The following is a description of a gene set: Genes containing one or more binding sites for (Vsx2) in their promoter regions (TSS -1000,+100 bp) as identified by GTRD version 20.06 ChIP-seq harmonization. Mouse Gene Set: VSX2_TARGET_GENES from publication Yevshin I, Sharipov R, Kolmykov S, Kondrakhin Y, Kolpakov F (PMID 30445619) species: Mus musculus, and this is the list of marker genes: Atp6v0e2, Dedd, Zfp472, Tdrkh, Pyroxd1, 1700065J11Rik, Zfp473, Ddc, Pdcd2, Six3os1 (NCBI Gene Id 77868), Icosl, Mrpl54, Elf2, Rad54b, Cactin, Gins4, Ecpas, Vrk3, Ash1l, Tipin (NCBI Gene Id 74321), H2bc15, Lrp2bp (Lrp2 binding protein), Skil, 5730596B20Rik, Mir1906-1, 4930512B01Rik, Etl4, Wscd2, Gm15340, Trrap, Dock5, Cipc, Siah3, Idh1, Inpp4b, Mdm4, Arhgap28, Bcar3, Nfyb, 1700113A16Rik, Rnf207, Zhx3 (zinc fingers and homeoboxes 3), Nedd4l, Trim33 (NCBI Gene Id 99609), Slc12a4, Cyb5r4, Crip1, Tlr3, Ndufa9, Wdr1, Gm21917, Gm13761, Slc16a3, Gm13648, Lmo2, Plcb3, Mrpl9, Rab3ip, Gm30382, Pkn2, Zfp595, Mir1191b, Alkbh1, Sec24d, Zcchc10, Mir34c, Rps6kb1, Mbd3l2, Snora28, Snx16, Zbed6, E130304I02Rik (NCBI Gene Id 78547), Otx2os1, Slc39a13, 4930461G14Rik, Cdh22, Elmo2, Gm11728, Myo3b (myosin IIIB), Zfp763, Dffa, Ulk4, Mutyh, Deptor (NCBI Gene Id 97998), Man2b2, Ascc1 (activating signal cointegrator 1 complex subunit 1), Mettl15, Epc2 (NCBI Gene Id 51924), Pnrc2, Elf3, Prdm9, Gpr85, Opn3, Nabp1, Cyp4b1-ps1, Palm3, D1Pas1, Grk5, Rpl35a-ps3, Kctd12, Tmem229b, Abcg2, Chp2, Krtap4-16, Mir195a, Fndc3a, Jund, Dlx1as, Tbc1d10a, Gm24432, Mif, Ubr4, Cfap77, Gm12229, Cdk2ap1rt, Gsto1, Fbxo9, Med18, Gm22215, Gm11536, 4632428C04Rik, Cyp2j13, Tmed6, Adprm, Gramd2b, Ampd2, Gm3143 (predicted gene 3143), Sf1, Gm13655, Slc35b1, Gm24616, Smim18, Prkar1b, Nat8f2, Mir6359, Rnf135, Gm11587, Mrpl22, Zfp532, Pecr, Bnipl, Epb41, Csrnp3, Mef2c, Txndc12, Enpp5, Ly96, Gm30948, Zfp982, Gm29246, Setd1b, Pgrmc2, Ier2, Gm24784, Gm16326, AI987944, Neurl4, Mdga1, Mir7009, Gli2, Cyrib, 5830454E08Rik, Haus3, Gypc, Gtf3c2 (general transcription factor IIIC, polypeptide 2, beta), Prkab2, Mab21l1, Rcc1, Calm3, Rbm14, Gm25724, Vars2, Rell1, Alyref, Gm24998, Trib3, 6530411M01Rik, Nup43, Rhox12, Tmem259, Gjd4, Ndnf, B9d1os, Snx17, 9030619P08Rik, Gm6394, Cdc7, Bcat2, Skida1, 2310014F06Rik, Tesk2, Bsdc1, Rmnd5b, Acoxl, Gm6139, Utp15, Rpl26, Poll, Bid, Bfsp2, Tead1, Gm23301, Platr9, Arl1, 1700058P15Rik (NCBI Gene Id 73377), Pip5k1c, Gm8242, Rbm28, Rbm25, Mir5130, Smoc1, Stk39, Pnma2, Dock6, Phrf1, Cabyr, Suclg1, Zfp974 (zinc finger protein 974), 5730488B01Rik, Gm29455, Ldlrap1, Osbpl10, Gm22042, Coro6, Anapc13, Tmem161a, Zzz3 (NCBI Gene Id 99926), Slc23a2, Cobl, Chmp4c, Med21, Dmap1, Brd3, Rorc, Zfp985, Vps13d, Adam22, Ttf1, Acvr2b, Mir496b, Trim47, Tmem131l, Nrg4, Gemin5, Ptgfrn (NCBI Gene Id 99830), Mir664, Jmjd6, Zfp989, Per1, Calu, Cldn22 (claudin 22), Gm28043, Katnal1, Cer1, Dnaaf2, Cdh6, Tardbp, Mcu, Ccdc25, Cep15, Dennd6a, Snord80, Ttll10, Acadm, Rps23-ps1, Nkx2-1, Pank1, Mlip, Tsr1 (NCBI Gene Id 216950), Zfp988, Lypd1, Tram1l1, Dnm2, Gata4, Ywhaq, Prtg, Gm10774, Gm9967 (predicted gene 9967), Gbf1, Gm7902, Zfp984, Cast, Col9a1, Isca1, Mat2b, Gm26447, Gatad2b, Samd7, Pbx2, Ubr1, Fam53c, F830115B05Rik (RIKEN cDNA F830115B05 gene), Triobp, Ptpre, F10, Dok5, Elmo1, Rnpep, 1700011L22Rik, Foxg1, Gm13429, Gbp11, Lrrc28, Trafd1, Sdk1, Gm18808, Mir124-2hg, Lactbl1, Fbxw17, Gm22205, Bola1, Gtf2i, Postn (NCBI Gene Id 99708), 1700003F12Rik, Mcmbp, Ifrd1, Rack1, Cs, 4833420G17Rik (RIKEN cDNA 4833420G17 gene), Bcl7c, Sh3bp1, Zfp703, Oosp3, Tmem144, Sf3b1, Knl1, B530045E10Rik, Mfap3l, Rpe, Tnfrsf22, Dpep1, Etv1, Mrps5, 4930518J20Rik, Insm2, Dock4, Gm12784, Fbrsl1, Park7, Gm13450, Tmem169, Spring1, Cga, Gm12703, Pkm, Thumpd3, Kctd15, Egf, Prkag2 (NCBI Gene Id 73700), Hyal3, Ogfrl1, Rreb1, Pnkd, Srsf3 (serine and arginine-rich splicing factor 3), Wdr73, Gatd3a, Gm12644, Mir690, Aire, Wdr44, Fam135a, Mrpl16, Crym, Tcte2, Camta2, Nkapl, Srpk1, Gm23202, Enah, Gm12101, C4bp, Map3k3, Cdk16, Hcrt, Isoc2a, Tex261, Gm23102, Ubxn2a, Rpia, D7Ertd443e, Mir135b, Fhl1, Or52e5, Kif27, Kif5c, Tspan18, Capns1, Fbf1, Zc3hav1, Krtap12-22, Rps19-ps11, 9330198N18Rik, Rptor, Esx1 (NCBI Gene Id 13984), Pex13, Zfyve16, Hsd17b4, Slc19a2, Gm22301, Nt5c3, Mta3, Krtap2-20, Chrac1, Ap2b1, Acvr1, Ifi30, D630039A03Rik, Slc9a2, Abhd3, Med6, Fcgbp, Acss2, Snap91, Hoxc12, Gm26832, Mvb12b, Cct6a, Ap1ar, Fam167b, Gm23212, Gm15541, Traj27, Ipo8, Osbpl3, Rnf8, Gm13147, Fam169a, Rab11fip3, Tmcc2 (transmembrane and coiled-coil domains 2), Cep120, Fzd2, Mreg, Kdr, Or5m13b, Rnf14, Svopl, Rpusd3, Meg3, Shroom3, Zcchc14, Kif18a, Atp6v1f, Trim6, Adgrl2, Sbds, Urgcp, Gas5, Bahd1, Thra, Gm15770, Phip, Mir370, Ptgr3, Zfp268, Kbtbd7, Itga3, Tanc1, Cyp2u1, Slc25a12, Fmo4, Pisd, Zscan5b, Gm6089, Mir7239, Tmem230, Or52n20, Zfp536 (NCBI Gene Id 78852), Trp53cor1, Tmem275, Mme, Fam131a, Zc3h11a, Trmt44, Gnas, Alas1, Taf1c, Pkdcc, Zfp1, 4833439L19Rik, Rab23, 3222401L13Rik, Lrriq4, Paqr8, Palb2, AU041133, Mfsd4b4, Platr16, Or1j11, Plxnc1, Rad54l (NCBI Gene Id 99991), Gpr153, Pomt2, Gm12508, Fryl, Calm2, Eps8l2, Hyou1, Cnot7, Nlgn2, Rcc2, Rapgef3os2, Atp6v1e1 (ATPase, H+ transporting, lysosomal V1 subunit E1), Nkx1-1, Usp46, Sfxn5, Zfp981, Gm11496, Mdfi, Gm5106, Lyg2, Traf6, Lix1, Bex2, Crebrf (NCBI Gene Id 77128), Stk36, Tti2, Spsb3, Drosha, 6430511E19Rik, Ifih1, Gm21411, Necab3, Stk35, Mir7687, Nkx2-4, Tafa3, Gm6695, Psph, Gm6034, Psmc1, Shld1, 9230109A22Rik, Mir7b, Snrpa, Tuba1b, Dcdc5, H2-T22, Tbx6, Gm23336, 1700067K01Rik, A430102K17Rik, Cd59b, Timm17a, Usp42, Rex2, Atad3a, 2900041M22Rik, Usp16, Mnx1, Hspa9, Lman2l, Vps35l (VPS35 endosomal protein sorting factor like), Nkx2-5, Lbx1, Sbf2, Myocd, Rarg, Fbxl3, Rps19, Trim62, Ppp4r3b, Rps2-ps5, Med11, Gm17202, Clvs2, Slco4a1, Hnf1aos1, Cimip3, Stk4, Rnf121, Snord78, Med23, Nipa2, Sos1, Abr, Mthfr, Gm19932, Smc3, Snord13, Camk1d, Ap3m1, Eml2, Tenm4, Urad, Ifitm10, Vsx1, Mapk1ip1l (NCBI Gene Id 218975), Pop5, Arhgap11a, Tshz1, Pias1, Sos2, Ppig, Uncx, Gm19721, Grid2ip, Hectd4, Mtch2, Ahcy, Fezf2, Ap3b1, Api5, Hnf4g, Tac1, Frat1, Phospho2, Lyn, Atg101, Coq10b, Elapor2, Tnfsfm13, Mrps10, Birc6, Arhgap1, Zbed5, Kpnb1, Prorp, Lcor, Gm6485, Gm26973, Fbxl4, Traj35, Or8d4, Gm43699, Rps17, Krt14, Cers5, 1700074A21Rik, Msx2, Lpcat2, Zfp335, Zfand3, Rfc4, Aldoc (aldolase C, fructose-bisphosphate), 1700027A07Rik, Gm5523, Gm13203, Eef1akmt1 (NCBI Gene Id 68043), Fcf1, Slc25a40, Rab8b, Dpysl4, Hars1, Or52b2, Ppp1r3e, H2-T10, Zscan2, Hmgcr, Gm26604, Emx2, Rnu11, Tead2, 1700123O20Rik, Ankrd13c, Pus10, Gm16041, Foxred2, Crxos, Palld, Golm2, Jmjd1c, Hacl1, Grip2, Mettl8, Rnf32, Atraid, Gm17430, Gng2, Txnl4b, BB019430, Gm22578, Trappc6b, Pcp2, Pdlim5, Usp50, Cfap46, Nbeal1, P3r3urf, Slc1a3, Emx2os, Fbxl22, Rsrp1, Sfpq, R3hdm2, 1700017J07Rik, Chaserr, Tenm3, Sgpp1 (NCBI Gene Id 81535), Ube3c, Polr1e, Polh, Aldoa, Dclre1c, Prune2, Azin2, Met, Sptbn1, Myo6, Nfu1 (NFU1 iron-sulfur cluster scaffold), Gm24726, Gdpd5, Tnks2, Csnk1a1, Kmt5c, Tatdn2, Hdhd2, Prss50 (serine protease 50), 1700016A09Rik, Ppp1r2-ps1, Abhd5, Gm10637, Oma1, Chst3, Mns1 (NCBI Gene Id 17427), Tigd3, Disp1, Lmo3, Thrap3, BB218582, Fxr1, Gm22362, Crem, Pmf1, Gm13889, Bnip3l, Mir124a-2 (microRNA 124a-2), Zfp706, Ppme1, Pax5, Cbfa2t2, Cntnap1, Ccni, Gm22915, Cdsn, Rere, Rbm47, Sh3bp5l, Tmem167b, Tuba1a, Fmnl3, Tasor, 2610027K06Rik, 1810062G17Rik, Apaf1, Nkx6-1, Zbtb20, Grik4, Zfp990, Zfp60, Gm16170, Reep3, Fendrr, Carmil1, Gucy2c, 1700012C14Rik, Cep170, Pramel13, Ttn, Timm10, Oas2, Klhl31 (kelch-like 31), Pacrg, Xrcc6 (X-ray repair complementing defective repair in Chinese hamster cells 6), A330074H02Rik, Blmh, Ttl, Ephx2, Tmem263, Opa3, Gssos2, 2510002D24Rik, Grin1, 4930405L22Rik, H1f10, Gid8, Txndc16, Nkain1, Snrk, Syngr3, Gmpr2, 1700105P06Rik, Aamp, Tcerg1, Asph, Tnk2, Mtarc2, Cdan1, Atp5f1a, Dst, Plcd1, Mir1936, Hnrnpdl, Gatad1, Dnajb4, Pcolce2, Cldn10, Tmem260, Dgkz, Mitf, Cers4, Lhfpl7, Gm12963, Mrpl15, Prx, Rxfp3, Ccr10, Chsy1, Napsa, G3bp2 (G3BP stress granule assembly factor 2), Zfp521, Aif1l, Gm5225, Gm26671, Or2i1, Tiam1, Tmub2, Trim3 (tripartite motif-containing 3), Mfn1 (NCBI Gene Id 69518), Zkscan5, Fmc1, Cyb5r1, Gtf3c1, Rnf25, Cryba4, Tmod1, Mmaa, 1700003D09Rik, Ush1c, Tnfrsf1b (tumor necrosis factor receptor superfamily, member 1b), Gm9754, Uchl1, Acyp2, Wnt10a, Fabp5, Clstn3, Tbcb, Tmem234, Tex12 (testis expressed 12), Neu2, Cetn3, Gm25703, Pax6, Smyd2, Esrp1, AI480526, Robo2, Elk1, A430005L14Rik, Aste1, Elovl6, Or5be3, Slc16a10, Tsfm, Ermard, Snx7, Mcrs1, Hcfc1r1, Itpkb, Aard, Parvaos (NCBI Gene Id 320920), Eif2b4, Scn2a, Acbd7, Gm16559, Rnf185, Mroh8 (NCBI Gene Id 629499), Tspyl2, Bag4, Nfatc4, Sephs2, Asap1, Zbtb24, Gm24382, Rbm26, Pprc1, Chil3, Gpr88, Kpna4, Ndufb4, Chd2, Bcar1, Cln8, Stambpl1, Tlr1, Gm2109, Tctn1, Zfp84, Cept1, Fgf1, Pogz, Mir34b, Krt222, Psmc3ip, Tmem222, Snx15, Gm24992, Lgi3, Lzts1 (leucine zipper, putative tumor suppressor 1), Krt73, Prelid3a, Rpl19, Tdh, Yif1a, Zkscan2, Rpl21, Pdzd11, Rpl41, Gm4419, Btc (betacellulin, epidermal growth factor family member), Gm21992, Mir7042 (NCBI Gene Id 102465631), Elavl4, Gm22571 (predicted gene, 22571), Tcn2, Plaat3, Lap3, 1700041I07Rik, Thsd7a, Zfp46, Cntn2, Cdkal1, Mrpl14, Mtdh, Mvb12a, Bloc1s3, Mob3a, Rpph1 (ribonuclease P RNA component H1), Cct4, Rbl2, Atp5mc2, Gtf2ird1, Rexo1, Got1 (NCBI Gene Id 14718), Ikzf1, Caprin1 (NCBI Gene Id 99144), Amt, Usp12, Cd96, Mkx, Hnrnph3, Zap70, Sgms1, 4930513N10Rik, Prpf8, Olfr1060-ps1, Mllt6, Ppp1r16a, Mir701, Gm10269, Trpm3, Nudt1, Gm26779, Gm3150, Mrps17, Wdr19, Foxm1, Fsbp, Gm19684, Rps27, Cdc25b, Zfp68, Nectin2, Dlg1, Zfp607b, Mlxipl, Anxa5, Katnip, Rcan1, Sgk2, Gm2979, Slirp, Lrp11, Pdlim2, Abcf3, Gm16160, Gzf1, Vasp, Ndufa7, Sms, Nectin3, Elac2, Tubd1, Abcc1 (NCBI Gene Id 94110), Hykk, Marchf9, Sall4, Pi15, Gm25296 (predicted gene, 25296), A230028O05Rik, Taf5, Pikfyve (phosphoinositide kinase, FYVE type zinc finger containing), Dclk2, Nhsl3, Pou2f1, Krtap12-20, Aldh3a2, Ssr3, Gdf3, Gm10171, Traj5, Gm20574, Snx14, Vmn2r71, Cecr2, Litaf, Zfp64, Cnnm3, 6030443J06Rik, Morc2b, Cep85, Cops7a, Gm12462 (NCBI Gene Id 102632357), Zfp93, Tnfsf12, Galnt7, Csn1s1, Gm7626, Zfp652, Nudt3, Gmppa, Fbxo27, Scaf8, Btf3l4, Bach2, C630028M04Rik (RIKEN cDNA C630028M04 gene), Smad6, Rft1, Mgat1, Zfp90, Lime1, A430035B10Rik, Pdss1, Bclaf1, Prim2, 1110004F10Rik, Dars2, Selenot, Gm42918, Rcor1, Stk38, Polr2j, Psmd9, Rps5, Zfp180 (zinc finger protein 180), Pld4, Usp1, Zfp59, Gm23205, Osbp2, 1810064F22Rik, Gm10248, Gm22365, Sorbs2, Mageb3, Tmem256, Otx2, Ticrr, Caap1, Mrps16, Blcap, 9330111N05Rik, Ctdp1, Larp4, Prmt5, Srm, Pde4dip, Gm13073, Cep131 (centrosomal protein 131), Serpinb1c, Gm25137, Slc6a8, Wapl, Adam19, Ccdc170, Marchf7, Alkbh5, Ptcd3, Usp33, Capn2, Fbxo33, Recql, Fxyd6, Ska2, Gm26802, Hnrnpc, Robo1, Gm24793, Ltbp1, Med16, Dbx1, 6330562C20Rik, Slc13a4, Depdc5, Gm2670, Pnisr, Setd2, Gm23746, Ripor2, Gmip, Fn3k, Ovol1, Gm5745, Lipt1, Mir1949, Fsd1, Izumo4, Syne2, Mmgt1, Snx5, Gm12690, Pacsin3, Zfp534, Tmem158, Gm23382, Lamtor4, Dop1a, Zfp276, Gm17102, Dhx32, Chd9, Haao, Smg6, Il22ra1, Uchl1os, Hnrnpl, Cmtm7, Tspan1, Pdyn, Mir376c, Camk2d, Rbbp7, Rpsa-ps11, Ms4a10, Acot8, Lats2, Tmem87b, Gm11797, Snord118, Lsm2, 4933431K14Rik, Cenpb, Mir7032, Gm3267, Atp5mc1, Nme5, H2ac5-ps, Tent4b, Srsf7, Sco1, 1700040D17Rik, Zfyve28, Tedc2, Mmut, Rps18-ps6, Sash1, Rpl15-ps2 (NCBI Gene Id 677193), Mgst2, Mindy1, Gm9387, Slc6a2, 1700071M16Rik, Cdh20, Atxn2, Tymp, BC006965, Dmrtb1 (NCBI Gene Id 56296), Atf1, 1600019K03Rik, Ren1, Xpr1, Tns1, Gtpbp10, Kazn (kazrin, periplakin interacting protein), Chrna1os, Crispld2, Rev3l, 5031415H12Rik, Sap25, S100a14, Impg2, Gm42573, Stat3, Spsb1, Tmem191, Ppp1r1b, Col2a1, Plch2, Gm22313, Vps39, Gm26202, Acin1, Eaf2, Rad21, Zdhhc21, Lrrc7, Dpp6, Cc2d2a, Npc1, Polr2i, Esrra, Fam178b, Xntrpc, 4930547M16Rik, Entrep1, Kremen2, 5930420M18Rik (NCBI Gene Id 319223), Traj28, Slc29a1, Zfp960, Smarca4, Phf19, C2cd3, Sh3tc1, Gm11465, Atp4a, Brd9, Gm26165, Cracd, Nol4, Tnfaip8, Col20a1, 1700063D05Rik, Gm4221, Nr6a1, Sstr5, Polr1a, Mettl23, Nebl, Coq10a, Gm9905, Pdcl, Sfi1, Pdlim1 (NCBI Gene Id 54132), Gm25835, Ift57, Orc5 (origin recognition complex, subunit 5), Rufy3, Npy1r, Parp2, Gm20618, Tmcc3, Fhl2, Lmna, Ypel3, Idua (iduronidase, alpha-L), Stat1, Dctn5, Dlx1, Ptpn3, Lsm10, Cdc42se1, Gosr1, 1600014C10Rik, Col16a1, Gm12002, Vipas39, Tsen15, Tmem198b, Gm22798, Gm14541, Hr, Ska1, Fgfr2, Maea, C430039J16Rik, Gabpb2, Cep57, Mir7650, Pld2, Dnajb2, B3gnt5, Eogt, Gm17491, Gm20548, Cd86, Altre, Zdhhc24, Igkv4-86, Zfp408, Gsk3a, Gm16876, AY702102, Cyp4f18, Aspm, Agpat3, Atf7ip, Llgl2, 2410021H03Rik, Gm16510, Aig1, Stag3, Gm5278, Wt1, H2ac21, Mri1, Tex264, Gprc5c, Luc7l2, Gm26583, Nudt18, Sinhcaf (NCBI Gene Id 56306), Pomgnt1, Gm11203, Mir497, Ppm1k, Mthfd1l, Xndc1, Osbpl8, Sc5d, Vsig8, Nucks1, Armc3, Ciz1 (NCBI Gene Id 72984), Slc39a2, Msgn1, Hdac7, Tmed4, Gm12676, Gm25697, Ttpa, Cilk1, Zfp991, Ptprd, Myo18a, Miga1, Kcnip2, Apold1, Rai1, Entpd1, Gna13, Rraga (Ras-related GTP binding A, NCBI Gene Id 68441), Wsb2, Mir6397, Hnrnph1, Boll, Rec114, Prpf38b, S100a3, Srsf4, Cacna1c, Gm25587, Tnfrsf18, Med27 (mediator complex subunit 27), H2bc18, Gm12689, Fgd4, Stt3a, Rnft1, Slc5a6, Jade1, Ldb1, Pym1, Rapgef4os3, Med24, 1700023G09Rik, Gm12297, Ndufaf6, 4930518I15Rik, Gm5141, Mfsd12, Kif20b, Timm44, Chtop, Camk2n1, Slc16a9, Polr3b